The following is a description of a gene set: A protein complex that contains at least CD40 (a cell surface receptor of the tumour necrosis factor receptor (TNFR) superfamily), and other signaling molecules. species: Mus musculus Mouse Gene Set: GOCC_CD40_RECEPTOR_COMPLEX, and this is the list of marker genes: Traf5, Birc2, Chuk, Traf2, Htra2, Ikbkb, Traf3, Cd40, Rnf31, Traf6, Diablo